The following is a description of a gene set: The large subunit of a ribosome located in the cytosol. species: Homo sapiens Human Gene Set: GOCC_CYTOSOLIC_LARGE_RIBOSOMAL_SUBUNIT, and this is the list of marker genes: RPL3L, RPL5, RPLP2, RPL18A, RPL17, RPL10L, RPL36A, UBA52, RPL12, RPL27A, RPL36AL, RPL39L, RPL39, RPL27, RPL13A, RPL28, RPL7, RPL31, TIFAB, RPL22, RPL11, RPLP0P6, RPL4, RPL13, RPL37 (ribosomal protein L37), RPL29 (ribosomal protein L29), ZCCHC17, RPLP1, RPL35, RPL35A, RPL6, RPL26L1, RPL8, RPL23A, RPL15, RPL7L1, RPL38, RPL18, RPL19, RPL10, RPL39P5, RPL7A, RPL30, RPL26, RPL34, RPL36, RPL23, RPL14, RPL10A (ribosomal protein L10a), RPL21, RPL37A, RPL3, RPL9, RPLP0, RPL41, RPL32, RPL24, RPL37AP8 (ribosomal protein L37a pseudogene 8)